Given this list of marker genes HNF1B, RTL1, HNF4A, CEL, HYMAI, DLK1, BLK, APPL1, NEUROD1, ZFP57, MEG3, PLAGL1, KLF11, PDX1, KCNJ11, INS, HNF1A, PAX4, ABCC8, PCBD1, GCK, here is a description of the gene set: Human Gene Set: HP_MATURITY_ONSET_DIABETES_OF_THE_YOUNG studied in species Homo sapiens The term Maturity-onset diabetes of the young (MODY) was initially used for patients diagnosed with fasting hyperglycemia that could be treated without insulin for more than two years, where the initial diagnosis was made at a young age (under 25 years). Thus, MODY combines characteristics of type 1 diabetes (young age at diagnosis) and type 2 diabetes (less insulin dependence than type 1 diabetes). The term MODY is now most often used to refer to a group of monogenic diseases with these characteristics. Here, the term is used to describe hyperglycemia diagnosed at a young age with no or minor insulin dependency, no evidence of insulin resistance, and lack of evidence of autoimmune destruction of the beta cells. Maturity-onset diabetes of the young